The following is a description of a gene set: Human Gene Set: HP_RHEGMATOGENOUS_RETINAL_DETACHMENT Rhegmatogenous retinal detachment species: Homo sapiens A type of retinal detachment associated with a retinal tear, that is, with a break in the retina that allows fluid to pass from the vitreous space into the subretinal space between the sensory retina and the retinal pigment epithelium., and this is the list of marker genes: TSPAN12, CTNNB1, LCA5 (lebercilin LCA5), LRP5, RPE65, COL2A1, COL9A1, FZD4, NDP (norrin cystine knot growth factor NDP), ZNF408, SPATA7, LRAT